Given this list of marker genes Slc39a4, Slc39a10, Rep15, Slc39a7, Slc39a11, Slc39a2, Steap3, Mmgt1, Mt3, Slc48a1, Abcc5, Ryr2, Slc30a9, Hsd3b3, Flvcr1, Abcb6 (ATP-binding cassette, sub-family B member 6), Hrh1, Inhca, Slc39a1, Slc39a13, Tmem163, Fthl17e, Atox1, Slc25a37, Slc25a28, Iscu, Mcoln2, Timd2, Sfxn1, Ftl1, Hfe, Atp7b, Nectin1, Trf, Slc30a2, Slc30a10, Atp2c1, Snx3, Abcc2 (NCBI Gene Id 12780), Meltf, Ap3d1, Slc41a2, Slc39a12, Slc31a1, Steap4, Slc46a3, Fxn, Hsd3b6, Heph, Hephl1 (NCBI Gene Id 244698), Hpx, Slc11a2, Slc30a3, Flvcr2, Slc39a5, Abcb7, Slc40a1, Scara5, Nos1 (nitric oxide synthase 1, neuronal), Slc46a1, Rab11b, Slc30a4, Pik3c2a, B2m, Tcn2, Slc39a6, Slc39a8, Slc30a5, Slc30a1, Hif1a (NCBI Gene Id 15251), Pgrmc2, Slc39a3, Slc30a7, Slc30a6, Tmem165, Trpm7, Arhgap1, Cblif, Asic3, Slc1a1, Ftmt, Fkbp4, Slc39a14, Hamp, Fth1, Slc22a17, Lmtk2, Cltc, Ifng, Lcn2, Atp7a, Slco2b1, Tfr2, Slc31a2, Hamp2, Slc39a9, Slc30a8, Mmgt2, Hsd3b2, Atp2c2, Steap1, Mcoln1, Slc11a1, Steap2, Myo1b, Dnm2, Ltf, Tfrc, Trpm2, here is a description of the gene set: The directed movement of transition metal ions into, out of or within a cell, or between cells, by means of some agent such as a transporter or pore. A transition metal is an element whose atom has an incomplete d-subshell of extranuclear electrons, or which gives rise to a cation or cations with an incomplete d-subshell. Transition metals often have more than one valency state. Biologically relevant transition metals include vanadium, manganese, iron, copper, cobalt, nickel, molybdenum and silver. species: Mus musculus Mouse Gene Set: GOBP_TRANSITION_METAL_ION_TRANSPORT